Given this list of marker genes Bbs1, Tomm40, Srp68, Golph3l, Zdhhc21, Ssr3, Pikfyve, Vps37c, Myo5b, Folr2, Tsc2, Vamp3, Glp1r, Atp13a1, Arl6, Cacng2, Ccl2, Nsf, Snap23, Amn, Itgb1bp1, Frmpd1, Zdhhc2, Cacnb3, Sec61a1, Vps37d, Snx27, Washc1, Cd24a, Cnst, Vamp2, Cdk5, Yif1b, Srp9, Rab10, Zdhhc3, Zdhhc19, Gripap1, Krt18, Zdhhc7, Grin2a, Mmgt1 (membrane magnesium transporter 1), Rab31, Maip1, Acsl3, Zdhhc15, Scarb2, Golga4, Arhgap44, Rtp2, Rabgef1, Rtp3, Tomm22, Rab11a, Get3, Rilpl1, Tmem147, Prepl, Bid, Pex26, Snap47, Atp2c1, Hspa4, Vps35 (VPS35 retromer complex component), Nacad, Tent2, Oxa1l, Inpp5k, Pex19, Agk, Dusp21, Epb41l1, Arl6ip1 (ADP-ribosylation factor-like 6 interacting protein 1), Ogt, Vamp5, Golph3, Pex5, Slc1a1, Sys1, Chm, Fyn, Zdhhc9 (zinc finger, DHHC domain containing 9), Timm29, Srp54a, Pkdcc, Romo1, Umod, Pex16, Itgam, Mtcl1, Nectin3, Pdcd5, Colq, Naca, Optn, Mylk, Gga2, Zdhhc23, Syne3, Gorasp2, Cdk5r1, Emc8, Timm13, Stx3, Zdhhc20, Stx1b, Vps37b, Grin3b, Usp17le, Tram2, Rab11b, Bcs1l, Emc3, Zdhhc24, Stom, Rab8b, Tram1l1, Cox18, Chp1, Prnp, Wdr83os, Gga1, Ncf1, Akt2, Timm10, Akap5, Pak1, Phaf1, Lyplal1, Trarg1, Mtch2, Atad1 (NCBI Gene Id 67979), Sorl1, Macf1 (microtubule-actin crosslinking factor 1), Srp14, Arfrp1, Caml, Pdzk1 (PDZ domain containing 1), Srp19, Clip1, Sgtb, Braf, Folr1, Commd1, Emc1, Cplx1, Moap1, Timm9, Dusp18, Ank3, Get1, Pex3, Zdhhc6, Zdhhc4, Kif13a, Sgta, Zdhhc25, Mtch1, Rftn1, Mal, Tcaf1, Lrrc7, Sptbn1, Cib1, Cln3, Ubl4a, Cwh43, Nsg1, Chmp4b, Rdx, Emc7, Kcne1, Npc1, Rtp4, Pard3, Srp54c, Nomo1, Zdhhc22, Lypla1, Rab5if, Bax, Pdcd5-ps, Zdhhc1, Emc6, Trmt10b, Ccdc47, Emc10, Kcnb1, Sec61g, Camk2a, Tmem126a, Micall1, Rab7, Bag6, Exoc4, Sec62, Rab34, Get4, Vps37a, Sec63, Sec61a2, Timm22, Grip2, Gga3, Emc4, C2cd5, Zdhhc18, Mief1, Rapsn, Tomm70a, Wnk1, Emc2, Adora1, Reep2, Samm50, Hspa5, Vamp4, Hsp90aa1, Grip1, Reep1, Mief2, Gdi1, Zfand2b, Csk, Mff, Bbs2, Clstn1, Emc9, Irgm2, Mapk10, Slc12a1, Aqp11, Cemip, Rab3ip, Tmco1, Zdhhc12 (zinc finger, DHHC domain containing 12), Sec61b, Ndufa13, Rilpl2, Tram1, Atp6ap1, Rab11fip3, Srprb, Rack1, Ap3b1, Srpra, Afdn, Slc51b, Blzf1, Rab8a, Zdhhc14, Rab26 (RAB26, member RAS oncogene family), Hras, Ncln, Srp72, Stx4a, Actr3, Erbb2, Sacm1l, Hpca, Oga, Fis1, Zdhhc11, Rab3gap1, Myo1c, Golga7b, Arpc2, Gorasp1 (NCBI Gene Id 74498), Golga7 (golgin A7), Rtp1, Rab3gap2, Scrib, Dmtn, Large1, Cacnb1, here is a description of the gene set: Mouse Gene Set: GOBP_ESTABLISHMENT_OF_PROTEIN_LOCALIZATION_TO_MEMBRANE The directed movement of a protein to a specific location in a membrane. species: Mus musculus